Given this list of marker genes NR1H3, OTUD1, RNF135, CASP1, GZMA, ZFYVE28, TRAM1 (translocation associated membrane protein 1), CNOT2, FAM199X, PDZD4, CLEC12A, ERO1A, PRKCQ, KIAA1549L, VAV3, UAP1L1, ZFP3, CDYL2, AMPD2, GPR155, DIPK2A, SLC35E2A, NR2C1, CPQ, BDH2, MACROH2A1, HMGCS2, ABHD14B, EDEM1, PDGFC (platelet derived growth factor C), RABEP2, RASGRP2, LPXN (NCBI Gene Id 9404), RIPPLY3, MEN1, TJP3, SDC4, PSEN2, FBXO27 (NCBI Gene Id 126433), IL2RA, SPATS2, ENTPD5, ALDH18A1, SNX13, TNFSF10, GRK4, RTN3, NUMB, LYVE1, N4BP2L1, TMEM229B, TYROBP, EYA2, TEF, IL17RE, UVRAG, ARHGAP25, USP33, SPNS3, B3GALT2 (NCBI Gene Id 90195), FLI1, DDX54, ALPK1, LRATD2, FAM117A, PIP5K1B, PPM1L, UNC119, SLA, P2RY14, GPR137B, SNAI3, LMO4, RIGI, TLE4, PDGFRB, COQ8B, DYNLT5, ADORA2A, CRELD1, MANBA, PRR13, CYFIP1, FN1, RESF1, ACOX1, LYN, SMAD4, CTLA4, SAA3P, KLHL24, PAPSS2, HPSE2, PYCR2, PPM1E, L3MBTL3 (L3MBTL histone methyl-lysine binding protein 3), BCL2L2, PIK3IP1, SGMS1, GOLM1, TLE6, IL18R1, FAM229B, CD47, LIPA, FSD2, CDKN1B, CYSLTR2, MYL9, CFH, PCSK1, SLC43A1, ELMOD3, CERS6, MARCHF6, ABHD15, EVA1B, ARRDC4, PRODH, EPSTI1, SH3BP5, STX2, RNASEL, AGAP2, GYPA, KMO, C3orf70, DPY19L3, EIF2AK3, PLD4, MGAT1, SLC49A4, MATK, HLA-B, HERC3, BLK, ABI1, RASAL1, CDC14B, PCK2, ESRP2, JAKMIP1, ST6GAL1, RPS6KA1, AMPD1, SEC24D, KRT76, PRKACB, VIM, DYNC2LI1, LIG4, ITGB7, SLC22A3, STX6, HSPBAP1, POMGNT2, SLC35D1, STAMBPL1, ENGASE, COQ8A, MYO1F, CPA3, RASA4, ZCCHC24, PPP3CA, CAPSL, ANKRD27 (NCBI Gene Id 84079), ACY3, GFRA1, IFNAR1, TBATA, IFNGR1, PRKX, STAT6, TRDMT1, PBXIP1, ACTN2, PCYT1A, CFHR4, CD163L1, RAMP3, TCN2, CD28, SCART1, VIL1, TMEM86A (NCBI Gene Id 144110), here is a description of the gene set: Human Gene Set: GSE27241_CTRL_VS_DIGOXIN_TREATED_RORGT_KO_CD4_TCELL_IN_TH17_POLARIZING_CONDITIONS_DN from publication Huh JR, Leung MW, Huang P, Ryan DA, Krout MR, Malapaka RR, Chow J, Manel N, Ciofani M, Kim SV, Cuesta A, Santori FR, Lafaille JJ, Xu HE, Gin DY, Rastinejad F, Littman DR (PMID 21441909) CD4+ T helper lymphocytes that express interleukin-17 (Th17 cells) have critical roles in mouse models of autoimmunity, and there is mounting evidence that they also influence inflammatory processes in humans. Genome-wide association studies in humans have linked genes involved in Th17 cell differentiation and function with susceptibility to Crohn’s disease, rheumatoid arthritis, and psoriasis1-3. Thus, the pathway towards differentiation of Th17 cells and, perhaps, of related innate lymphoid cells with similar effector functions4, 5, is an attractive target for therapeutic applications. Mouse and human Th17 cells are distinguished by expression of the retinoic acid receptor-related orphan nuclear receptor RORγt, which is required for induction of IL-17 transcription and for the manifestation of Th17-dependent autoimmune disease in mice6. By performing a chemical screen with an insect cell-based reporter system, we identified the cardiac glycoside digoxin as a specific inhibitor of RORγt transcriptional activity. Digoxin inhibited murine Th17 cell differentiation without affecting differentiation of other T cell lineages and was effective in delaying the onset and reducing the severity of autoimmune disease in mice. At high concentrations, digoxin is toxic for human cells, but non-toxic synthetic derivatives, 20,22-dihydrodigoxin-21,23-diol (Dig(dhd)) and digoxin-21-salicylidene (Dig(sal)), specifically inhibited induction of IL-17 in human CD4+ T cells. Using these small molecule compounds, we demonstrated that RORγt is imporant for the maintenance of IL-17 expression in mouse and human effector T cells. These data suggest that derivatives of digoxin can be used as chemical probes for development of RORγt-targeted therapeutic agents that attenuate inflammatory lymphocyte function and autoimmune disease. studied in species Homo sapiens Genes down-regulated in polarizing CD4 Th17 cells: wildtype untreated versus RORC knockout treated by digoxin.